The following is a description of a gene set: N-glycan biosynthesis Human Gene Set: WP_NGLYCAN_BIOSYNTHESIS studied in species Homo sapiens, and this is the list of marker genes: MPI, ALG8, MPDU1, MGAT4A, ALG14, RFT1, MAN2A1, DPM2, MGAT2, FUT8, DOLPP1, MGAT4C, GANAB, STT3A, DDOST, MGAT4B, MOGS, MAN1C1, ALG6, SRD5A3, TUSC3, GMPPA, MAN1A2, PMM2, ST6GAL2, B4GALT3, B4GALT1, MGAT1, ALG12, MAN2A2, MAN1A1, ALG5, DPAGT1, RPN2, ALG13, MAN1B1, DAD1, MGAT4D, ALG11 (ALG11 alpha-1,2-mannosyltransferase), ALG10B, GPI, ALG2, B4GALT2, ALG1, GMPPB, DPM3, MGAT5, MGAT5B, ST6GAL1, STT3B, DPM1, ALG10, DOLK, ALG3, RPN1, MGAT3, ALG9